Given this list of marker genes MARS2, GPCPD1, HAS2, CNOT6L, PBX2, SIGLEC14, PLXND1, PEG10, DMD, ARHGEF38, KLF9, CARNMT1, SPRYD4, COL4A1, SALL3, KCTD21, ADAMTS8, GNG5, BEND4, ERO1A, BIN3, HOOK1, BEGAIN, RUFY3, PLA2G3, DDI2, C8orf58, ADAMTS15, XKR8, RNF20, GAS7, EEA1 (early endosome antigen 1), DLST, DTX2, ABCC5 (ATP binding cassette subfamily C member 5), ZNF710, PTAFR, CD59, USP24 (NCBI Gene Id 388634), C15orf39, FBXL12, HIF1AN, MAPK6, MRS2, ADRB3, EDEM3, TSEN34, CDKN1A, IGDCC3, ACER2, OSMR, E2F6, TSPEAR, LAMP2, HDX, SLC20A1, STIMATE, LIPH, RSPO2, CLDN12, GJC1, COL27A1 (collagen type XXVII alpha 1 chain), APBB3, PIK3IP1, ZSWIM5, PLPP5, CCNJ, GDF6, ELP1, PARPBP, DNAJC1, CRTAM, EIF4G2, SALL4, NR6A1, B3GNT7, CPEB1, USP44, PIGA, FZD4, PALD1, MTDH, ZBTB5, DDX19B, MAP3K9, SEMA4C, VIRMA, UTRN, TET3, PBX1, COL3A1, FAXC, FASLG, LIN28A, LIMD2, YOD1, PBX3, THOC2, NEK3, PLPP6, AEN, CLCN5, AHCTF1, MBD2, ACTA1, ABL2, HDLBP, C19orf47, RAB8B, SLC10A7, HIP1, ZBP1, CCND2, NPHP3, TRIM67, PXT1, CEMIP2, POGZ, CLP1, HMGA2, NIPAL4, SRGAP1, LBR, ERCC6, COL4A2, NAP1L1, ATL2, ITGB3, EEF2K, SMIM3, SMARCAD1, PRSS22, IL13, MAP4K3, ZNF512B, C14orf28, E2F5, SIGLEC5, LRIG2, LPGAT1, GYG2, AMOT, SENP2, ELF4, GTF2I, UGCG, LINGO1, SNX30, KDM3A, ANKRA2, ABCB9, CEP120, GPR26, STXBP5 (syntaxin binding protein 5), RASGRP1, TMPRSS2, STX3, DTX4, CHD4, HSPA14, AKAP6, XK, ZNF784, UHRF2, GAN, IGF1R (NCBI Gene Id 51049), PCGF3, SOCS4, FGF11, HOXD1, COL1A2, CPA4, ZNF516, FIGN (fidgetin, microtubule severing factor), RFX6, ENTPD7, E2F2, PLEKHA8, AGAP1, RICTOR, HAND1, IGF2BP3, ZFYVE26, EDN1, CDC25A, ACVR1C, ABT1, CPEB2, AP1S1, TAF9B (NCBI Gene Id 51616), PCDH19, DVL3, CDC34, SKIL, DLC1, KCNC2, RDX, ARK2C, COL4A6, ERCC4, DUSP1, MDM4, SUB1, SLC25A27, SLC38A9, RBFOX2, SLC2A12, HECTD2, STARD9, GPATCH2, MIB1, IMPG2, BACH1, SCN4B, FRAS1, PLEKHO1, FZD3, TMPPE, MYCN, ZNF322, CADM2, CBX5, RGS6, PEX11B, PLXNC1, STRBP, MED8, FRMD4B, DDX19A, COIL, HOXA1, TMOD2 (tropomodulin 2), GXYLT1, PXDN (peroxidasin), MAPK8, TNFSF9, PRTG, ATP2A2, SLC5A6, TTLL4, EFHD2, DCAF15, STK40, NRAS, NME6, PTPRD, TRIM71, GALNT2, THRSP, AGO4, INSR, FNIP2, PLEKHG6, DPP6, ZNF644, RGS16, TMEM65, KLHL31, POLR3D, DNAJA2, TGFBR1, ZBTB8B, CCL7, ASAP1, KCTD17, ZNF583, TMC7, NME4, BZW1, CASP3, PRRX1, ONECUT2, RAB11FIP4, DNA2, GCNT4, NKAPD1, OSBPL3, ARL5A, TGFBR3, SDK1, IGDCC4, CEP135 (NCBI Gene Id 9662), FAM135A, CD164, POLL, SLC5A9, GNPTAB, PLAGL2, FNIP1, SENP5, SLC31A2, IGF2BP1, KLF8, ZNF275, DIP2A, GATM, B4GAT1, PAPPA, ARID3B, GFM2, DHX57, TMEM121B, FNDC3A (NCBI Gene Id 22862), MASP1, IRS2, PDPR, CERCAM, RALB, STARD13, SLC35D2, IGF2BP2, WNT9B, GALNT1, ENTREP2, NYNRIN, ARMT1, HIC2, VCF1, SLC16A9, LIN28B, ARHGAP28, SNX16, NHLRC3, ATP8B4, TBKBP1 (NCBI Gene Id 9755), MMS22L, TMEM167A, IQCB1 (NCBI Gene Id 9657), CLDN16 (claudin 16), SMC1A, ADRB2 (adrenoceptor beta 2), PPP1R15B, GALC (galactosylceramidase), PGRMC1, GABBR2, SFMBT1, PDE12, NGF, ZNF280B, OPA3, LRIG3, KLHDC8B, FIGNL2, USP38 (ubiquitin specific peptidase 38), PPP1R16B, RIMOC1, XRN1, PABIR1, CERT1 (ceramide transporter 1), AMT, KCNJ11, SLF2, LEPROTL1, here is a description of the gene set: from publication Chen Y, Wang X (PMID 31504780) Genes predicted to be targets of miRBase v22 microRNA hsa-let-7d-5p in miRDB v6.0 with MirTarget v4 prediction scores > 80 (high confidence targets). studied in species Homo sapiens Human Gene Set: LET_7D_5P